The following is a description of a gene set: Nuclear receptors meta-pathway Human Gene Set: WP_NUCLEAR_RECEPTORS_METAPATHWAY species: Homo sapiens, and this is the list of marker genes: CUL1, SLC39A13, SLC2A5, TSC22D3 (NCBI Gene Id 64477), SLC2A8, SMARCA1, HGF, SLC5A5, SLC26A2, STOM, BIRC3, ABCB4 (ATP binding cassette subfamily B member 4), TGFB2, SLC6A17, SRXN1, KEAP1, CBR1, CES5A, ANGPTL4, ABCB1, UGT1A4, POLK, MGST1, CYP4F12, CYP4A11 (cytochrome P450 family 4 subfamily A member 11), SLC27A1, APOA2, SLC39A14, SRPX2, S100P, KAT2B, NR1H3, B3GNT5, IL12A, SLC27A5, CES4A, TGFA, PDK4, GCLM, SLC39A2, FASN, SLC6A9, ME1, STAT3, CYP2C19, MAFF, SLC39A4, SLC6A5, TGFB1, ESR1, AIP, SLC2A13, CYP2C9, APOA5, FTH1, MAFG, SLC39A1, SOD3, IL12B, CBR3 (carbonyl reductase 3), AKAP13, BAX, GSTP1, SLC6A19, CYP7A1, PLTP, PRDX6 (NCBI Gene Id 9588), TNF, CYP3A7, CYP2A6, TNS4, SLC19A2, IL1B, GSTM2, LRRC8A, GSTA1, IP6K3, CDC42EP3, UGT1A1, FGFBP1, SLC7A11, SERPINB9, SLC5A11, IRS2 (insulin receptor substrate 2), CDK1 (cyclin dependent kinase 1, NCBI Gene Id 983), HSP90AB1, ARL5B, ACADM, HMOX1 (heme oxygenase 1), TGFBR2, SERPINA1, PMP2, EP300, EGR1, SLC39A11, IL11 (NCBI Gene Id 3589), CES2, SLC39A6 (solute carrier family 39 member 6), POU5F1, SLC5A10, CYP3A4, GSTA3, FABP1, VDR (NCBI Gene Id 7421), SLC6A16, SCNN1A, PRDX1, GSTM4, SLC5A1, EPHA3, FKBP5, CYP8B1, NR0B2, BHLHE40, GPAM, CCND1, NR1H4, JUND, EDN2, SP1, SLC10A1, PRRG4, SLC5A12, NCOA1, SLC2A1, MFGE8 (NCBI Gene Id 54740), IL2, TNFAIP3, SEC14L1, CYP2B6, ABHD2, ZIC2, CDK4, SLC39A8, GGT1, ADGRF4, GSTT2, NR3C1, CYP3A5 (NCBI Gene Id 1577), NCOA3, PTGS2, PPARA, ABCG5, ABCC5, IFNG, CDC37, SLC6A15, MYOF, CES3, UGT2B4, SLC2A7, EHHADH, HSP90AA1, TXN, SLC5A7, NFKB2, AHR, CPT1A, SCP2, ABCB11, CYP1A2 (NCBI Gene Id 1544), SLC5A6, UGT1A7, FTL, NCOA6, SLC39A10, NFE2L2, SLC39A3, SREBF1, SLC39A9, AGER, DNER, ADH7, PLK2, EPHA2, SLC39A12, NCOA2, GSTA2, PSMC5, HSPA1A, FOXO1 (forkhead box O1), KLK15, AHRR, SLC6A7, EPB41L4B, SLC2A10, UGT2B7, DNAJC15, HES1, PTGR1, SLC6A3, NQO1, SLC6A8, SLC5A8, SNAI2, CES1, SQSTM1, SULT1A1, SLC2A9, SLC6A11, KTN1, SLC5A9, MGST3, NRG1, TGFBR3, GPX3, APOA1, TXNRD3, SLC6A4, GSTM5 (glutathione S-transferase mu 5), BIRC2, SRGN, SLC2A4, SLC2A2, CDKN1B, G6PD, SLC2A6, SLC5A4, SMC1A, CYP1A1, PPARD, ETNK2, IL17B, CAVIN2, IGFBP1, SCD, PCK1, PTPA, DNAJC7, SLC6A13, AMIGO2, ALOX5AP, GPX2 (NCBI Gene Id 2877), CCL20, SLC6A1, CYP1B1, CPT2, SLCO1B1, SLC2A14, HBEGF, APOC3, ACOX1, NR1I3, DNAJB1, ANKRD1, PPARGC1A, ALAS1, CDKN1C, ENC1, RGS2, SPRY1, SLCO2B1, GSR, PDE4B, GCC1, ACAA1, SLC6A18, SPINK13, BAAT, GSTA5, SLC39A5, ARNT, SLC39A7, GSTA4, ABCG8, UGT1A9, SLC2A12, PTGES3, BLVRB, GSTM1, SLC2A11, SLC2A3, DBI, GPR153, SULT2A1, UGT1A6, ALDH3A1, FGD4, THBD, PDGFB, CPEB4, SLC7A5, FGF19, SLC6A6, ABCC4, SRC, PPP1R14C, NRIP1, RXRA, NR1I2, EGFR, ABCC2, GADD45B, SLC5A3, SERPINB2, SLC6A14, SLC6A2, JUN, GSTM3, NAV3, JUNB, CAP2, PGD, TXNRD1, ABCC3, FGF13, GCLC, SLC6A20, CCL2, MGST2, ACKR3, SLC5A2, SERTAD2, MYC